The following is a description of a gene set: EGFR interacts with phospholipase C-gamma Human Gene Set: REACTOME_EGFR_INTERACTS_WITH_PHOSPHOLIPASE_C_GAMMA studied in species Homo sapiens, and this is the list of marker genes: EREG, BTC (betacellulin), PLCG1, EGF, TGFA, AREG, HBEGF, EGFR, EPGN